The following is a description of a gene set: The chemical reactions and pathways involving imidazoles, five-membered organic heterocycle containing two nitrogen atoms at positions 1 and 3, or any of its derivatives; compounds containing an imidazole skeleton. Human Gene Set: GOBP_IMIDAZOLE_CONTAINING_COMPOUND_METABOLIC_PROCESS studied in species Homo sapiens, and this is the list of marker genes: SLC29A4, HDC, HNMT, CARNMT1, AMDHD1, PRG3, FTCD, TRH, HAL, UROC1, CARNS1, SLC22A3